The following is a description of a gene set: p27-Cell cycle G1/S. Pathway ID: N00091. Pathway type: Reference. Pathway class: nt06261 Gastric cancer. Human Gene Set: KEGG_MEDICUS_REFERENCE_P27_CELL_CYCLE_G1_S species: Homo sapiens Pathway Definition from KEGG: (SCF+SKP2) -| CDKN1B -| ((CCNA,CCNE)+CDK2) -> RB1 // E2F, and this is the list of marker genes: E2F1, CCNA2, RB1, CCNE1, E2F2, CDK2, CUL1, CCNE2, CDKN1B, E2F3, CCNA1, SKP1, SKP2, RBX1